Given this list of marker genes PUS1, DOCK9, FLNA, NFKBIA, EIF4E2, FUCA1, ATP10A, MAF, SLA2, RASA3, ADAMTS6, SNHG8, PARP11, CEPT1, ZFAND6, ATP8B2, RPS18, HCP5, GYPC, PDE4B, BTN3A3, RGS19, FOXO1, RPL31, CTSL, S100A6, RPL13A, MFNG, PGAP1, ZNF883, LRRN3, FXN, GPA33, COTL1, SFMBT2, LTA, CD55, CBLB, CCR7, ZNF16, LDLRAP1, GNL3, TRIM69, HCFC2, ZNF229, TSIX, SQOR, RPL6, PRORP, RPL12, GBP4, YTHDC2, PABPC1, HLA-J, HLA-G, TLK1 (NCBI Gene Id 9874), RPL32, SAMHD1, RIMS4, ZNFX1, NMRK1, CAPN2, TMEM128, CFP, IFIH1, EEF1G, P4HA1, MLLT3 (MLLT3 super elongation complex subunit), PLAC8, LPIN1, CD27, CIB1, NOP53 (NOP53 ribosome biogenesis factor), RPS15A, IL12RB1, RPL13, BMS1, AP3M2, RPL9, LRRC8C, S100B, ARHGAP45, PLEKHA2, LRRC8D, POLR3E, EEF2, DEF8, APRT, CNIH4, HLA-B, CNOT11, RPLP1, PSME2, IKZF4, FOXP1, PNP (purine nucleoside phosphorylase), MPZL3, EPSTI1, GGT1, AREL1, LRIG1 (NCBI Gene Id 26018), GPR155, CD200R1, FBXO34, XIST, DPH5, MGAT1, RGS1, E4F1, RPL29, TOMM5, TES, BTG1, ZNF302, TUBA4A (tubulin alpha 4a), SEMA3A, NPAS2, PYHIN1, RPS6KA3, RLN1, RPL7A, PLEKHO1, GIMAP8, EPB41, MPP7, UBALD2, SUSD3, RPS10, KDM7A, PFDN5, RASSF2, SMURF2, ACAA1, EIF3K, TSPAN14, CTSZ, IMPACT, RSAD2, LFNG, ANK3, FBLN7, LPIN2, RNF213, BIN1, SPATA13, S1PR1, C11orf21, NKIRAS1, KIAA0513, ERAP2, APOL3, PANK4, RPS19, CD48, AUTS2, TXK, IL4R, NELL2, ESYT1, TRMT10C, TPP2, RPLP2, LITAF, SPIN3, KISS1R, NOG, UPP1, STIM2, RPL30, COX7C, HEBP1, EIF3F, IL27RA, ADD3, ELMO1, RGS16, RPL17, C17orf49, GIMAP2, COL1A2, SEMA4C, ANXA6, BAG3, GMPPA, ARID5A, INPP4B, ERMAP, LIPA, LAMP3, CERS2, SPON1, PAG1, SMIM20, FYB1, here is a description of the gene set: Monocytes mature tom acrophages in the presence of the lineage determining cytokine M-CSF. They can be further polarized into M1 or M2 macrophages with distinct functional properties. We used microarrays to detail the global programme of gene expression underlying macrophage maturation and polarization and identified distinct classes of up-regulated genes during this process. Human Gene Set: GSE5099_CLASSICAL_M1_VS_ALTERNATIVE_M2_MACROPHAGE_UP studied in species Homo sapiens Genes up-regulated in macrophages: classical (M1) versus alternative (M2). from publication Martinez FO, Gordon S, Locati M, Mantovani A (PMID 17082649)